The following is a description of a gene set: Human Gene Set: GSE3982_DC_VS_CENT_MEMORY_CD4_TCELL_DN In the present study we used Affymetrix oligonucleotide microarrays to produce gene transcription profiles for the major leukocyte types in humans. This comprehensive dataset enabled us to not only establish which genes were expressed in each leukocyte type, but also which genes were expressed in each subset after activation. The used of a comprehensive dataset of gene profiles from all the major human leukocyte subsets enabled a novel and powerful means for identification of genes associated with single leukocyte subsets, or different immune paradigms. species: Homo sapiens from publication Jeffrey KL, Brummer T, Rolph MS, Liu SM, Callejas NA, Grumont RJ, Gillieron C, Mackay F, Grey S, Camps M, Rommel C, Gerondakis SD, Mackay CR (PMID 16474395) Genes down-regulated in comparison of dendritic cells (DC) versus central memory CD4 T cells., and this is the list of marker genes: CD200, PMP2, CDCA4, SRRT, TCOF1, SLC44A4, NOL9, ZNF266, MORC4, RPS27, ICE2 (NCBI Gene Id 79664), NAP1L2, SLAMF1, AOC2, USP9Y, PLEKHG3, HHIPL2, MED6, TPT1, CLCN2, ZNF136 (zinc finger protein 136), FCMR, IL6R, PTCH1, ARID5B, EIF4EBP2, GABBR1, LCK, INAVA, ZNF506, ASMTL, BBS1 (NCBI Gene Id 79702), AP1M2 (adaptor related protein complex 1 subunit mu 2), PMS2P5, MLLT10, RND3, HOXB9, EPPK1, ICOS, ARF1, FRMPD1, ARHGEF6, THPO, FTCD, IL24, LDOC1, CAMTA1, NUFIP1, KRI1, RPL39, TMSB15B, FAM117A, STON1, DDX18, CDK11A, TRAPPC2, CCDC177, IFI44L, ZNF391, ZEB1 (NCBI Gene Id 6935), ARHGAP35, GVINP1, MEOX1, ZNF337, MTRF1, ZNF44, VPS13D, TSPOAP1, TFF3, DENND1C (NCBI Gene Id 79958), DPY19L2P2 (DPY19L2 pseudogene 2), C21orf91, ZNF91, CNKSR1, HAUS5, ALDH1A3, LARS1, RBM14, DYRK2, PAX3, PRKAA2, LRRC1, THOC5, DEFA4, ALDOC, ARHGEF18 (Rho/Rac guanine nucleotide exchange factor 18), S1PR1, C2CD3, FBXL7, HLA-A, PLCG1, RPL6, SEPTIN9, ANXA6, SPTBN1, MOGS, IQCB1, GOLGA8B, PCDH8, NAP1L3, ARHGAP15, IPCEF1, SLC6A16, S1PR4, SLC38A1 (solute carrier family 38 member 1), EDEM1, SCGB1A1, SRSF5, PAXIP1, CHN1 (chimerin 1), GRM5, RPL36, CSGALNACT1, TWIST1, TPM3, ZNF611, C2orf68, TNNI3K, FOXJ2, IL13RA2 (NCBI Gene Id 3598), HSPA1L, ARHGAP5, KLF2, PDE4B, IL18R1, SPRR3, TSPYL2, PPP4R3B, RETREG3, IGHV5-78, AKT3, GIMAP6, SP140, FTSJ1, SIK3, FSTL3, RAPGEF6, APOBEC3G, WAS, RPL26, CASP6, EZH1, DIDO1, CEP43, COX10, ZNF451, CHMP7, TRA2A, ZNF264, CLDN16, EPM2A, SEMA4C, CELF2, GLOD4, DLG3, KAT6A, ZC3HAV1, H2AP, AMIGO2, WWC3, C10orf95-AS1, THOC2, LRFN3, ZDHHC11, TPR, EFHC2, PRKCH, ZNF22, PCID2, FLT3LG, MAN1C1, ITGA4, BBS9, TSPAN6, LINC01278, OAS2, CD3E, TLK2, FOSL2, ZNF131, RPS28 (ribosomal protein S28), TIPRL, DPP4, FOXO1, KIT, GALNT10, VTCN1, KHDC4, GIMAP5, NT5E, TSHR, CUTC, GRK6, URI1, SEMA6A, ZNF587, LIME1, BTN3A3, TRAT1, TXK